Given this list of marker genes Terb2, Nup98, Sun1, Majin, Spdya, Rad21l, Terb1, here is a description of the gene set: studied in species Mus musculus Mouse Gene Set: GOBP_TELOMERE_TETHERING_AT_NUCLEAR_PERIPHERY The process in which a telomere is maintained in a specific location at the nuclear periphery.